The following is a description of a gene set: studied in species Homo sapiens Human Gene Set: CUI_DEVELOPING_HEART_LEFT_VENTRICULAR_CARDIOMYOCYTE from publication Cui Y, Zheng Y, Liu X, Yan L, Fan X, Yong J, Hu Y, Dong J, Li Q, Wu X, Gao S, Li J, Wen L, Qiao J, Tang F (PMID 30759401), and this is the list of marker genes: ESAM, ISOC1, GJA1, SLIT2, RAMP2, HES1, IRX3, COLEC11, CXCL14, KCNJ2, CCL2, EMCN, NPPC, TRDN-AS1, POSTN, TMEM88, PLK2, SOX11 (SRY-box transcription factor 11), CTHRC1, COL3A1, BRIP1, MYH7, SOX4, HAPLN1, TFPI, CRNDE, HAND1, PHLDA1, ANXA1, LGALS1, TM4SF1, TRAIP, PLXND1, ENG, S100A11, SCUBE3, THY1, CMC1, ECSCR, PLVAP